Given this list of marker genes Cma1, Mindy1, Camk2d, Eif3m, Agbl5, Zfp696, Gas2, Fas, Hyal1, Slc35b4 (solute carrier family 35, member B4), Polr1c (polymerase (RNA) I polypeptide C), Srebf1, Dnaja1, Slc25a20, Psmd5, Cbx4, Ufd1 (ubiquitin recognition factor in ER-associated degradation 1), Sec23ip, Gm11626, Aim2, Mob1a, Eif4a3, Atf2, Aaas, Atad2, Vps4b, Zfp750, Gm12671, Tspan11, B130034C11Rik, Rgs18, Huwe1, Zkscan2, Fbxw22, Lce3c, Dpf2, Shfl, Tomt, H2-K2, Rhbdf1, Tacc3, Sec16a, Nlrx1, Rps3a1, 1700016P03Rik, Ubr1, Thsd7b (thrombospondin, type I, domain containing 7B), Aspa, Mms22l, Slc22a12, 4930515G01Rik, Rrp1b, Cask, 4933439C10Rik, Gm8066, Cul9, Sardh, Tef, Dnajc9, Klk5, Spdl1, Zfp335os, Smc1b, 2810402E24Rik, Kcnj15, Slc39a9, Cdk12, Bend3, Sympk, 4833439L19Rik, Angel1, 6430590A07Rik, Fosl2, Mink1, Ssbp1, Ddx23, Gm11993, Sorbs2, Mrpl57, Zfpm1, Gm28047, Cntln, Fam234a, Thap2, Tas1r1, Usp50, Ints13, Uap1, Irx2, Cryba1, Gm47512, Phlda3, Cfap161, St6galnac6, Atpaf1, Cntnap2, Opcml, Gm11185, Rictor, Cyfip1 (NCBI Gene Id 29878), Ift57, Cyb5d1, Ssr4, Spata2, Hspa4, Fam120a, Or8b12, Plekha7, Irag1, Dglucy, Stk11ip (serine/threonine kinase 11 interacting protein), Mau2, AA543401, Gm7164, Gm53, Uba6, H2-M2 (NCBI Gene Id 14990), Ddhd2, Gm4994, Hccs, Eif1-ps3, Trim35, Rpl10a, Ss18l2 (SS18, nBAF chromatin remodeling complex subunit like 2), Cnppd1, Kin, Slc1a2, Dusp26, Cct5, Gm9531, Mir3092, Nipsnap3a, Wrap53, Grk4, Mroh4, Gpr119, Rfk, Vtn, 4930539J05Rik, Hsbp1, Dlec1, 4930589L23Rik, Mroh5, Kpna3, Ctxn1, Cit, Septin7, Hk1, Gm12295, Gm13261, Kmt5b, Zbtb40, Alcam, Calm3, Ino80e, Cdc45, Cct8, Pcsk2os2, Sap18 (Sin3-associated polypeptide 18), Prdx3, Mast4, Snhg6, Srpk2, Arf3, Meig1, Stxbp4, Atp5f1c, Sgcb, Stard3nl, Txndc12, Naa30, Supt5, Cd86, Dynll1, Ppfibp1, Lman2l, Vezt, Gm20186, Pdia5, Brd2, Cdc5l, Snf8, Sgk2, Tktl1, Asxl1, Slamf9, Fam228b, Ikzf5, Gpcpd1, 3110083C13Rik, Mapk8ip3, Cnot3, Cdk8, Copb2, Slc12a9, Urb2, Gm19057, Dars1, Akap11, Pign, Phlpp1, Noa1, Tspan2os, Gm15576, Tipin, Ifi30, Cenpt, Mtmr3, Ssmem1 (NCBI Gene Id 75647), Lsm3, Xpc, Cox11, Ccdc92, Cpeb3, Hspa1b, Dennd2c, Agtpbp1, Pfkfb2, Mir7014, Nr3c2, Nubp2, A630023P12Rik, Rpl27, Puf60, Mir5133, Kazald1, Mkx, Tada3, Zfp661, B630019A10Rik, Smtn, Anapc13, Naa38, Rasl10b, Arap1, Lamp1, Senp2, Sidt2, Glmn, Wif1, Atpsckmt, Rnf8, Phf12, Ei24, Nudt19, Rangap1, Kdm1a, Smg5, Polr2l, Frmd4a, Med22, Phf19, Snord87, Tardbp, Dusp2, AY702102, Apoc2, Gm7933, M1ap, L1td1, Nuf2, Wdr11, Hc, Mcph1 (NCBI Gene Id 71346), Gm12503, Plcb1, Mgam, Acox1, Pum3, 4930401O10Rik, Agl, Trp53i13, Trim28, Tmem169, Fnip2, Thap12, Cetn3, Rfx7, Corin, Ldlrad2, 4930425O10Rik, Foxa2, Sned1, Cspp1, Mrpl40, Micos10, Exo5, Yipf3, Adipoq, 1700025G04Rik, Mapk14, Mpc2, Focad, AW551984, Ppp4r3b, Gm18382, A630023A22Rik, Pls1, Katnal1, Gm29398, Clk1, Gm32200, 1700112K13Rik, Adnp, Fgfr1, Cpne2, Vps13d, Qrich1, Irx5, Snx1, Bap1, Pms2, Rfx1 (regulatory factor X, 1 (influences HLA class II expression)), Rbm15, Ppp1cc, Bbc3, Fkbp5, Gm10638, Slc4a2, Csnk1g3, Zfp414, Nmrk1, Nsun3, Atf7, Dhx29, Ciapin1, Rpe (ribulose-5-phosphate-3-epimerase), Naa35, Rbm39, Ankfy1, Oxct1as, Mir3107 (NCBI Gene Id 100526510), Styxl1, Uqcc6, Dock3 (NCBI Gene Id 638531), Rab3b, Thap7, Fam110b, Depdc1a (DEP domain containing 1a), Arhgef40, Smarcc1, Nxpe4, Ano6, Gm26560, 9030622O22Rik (NCBI Gene Id 71570), Rpl26, Smg9, A530072M11Rik, Myo7a, 1110002J07Rik, Inpp4a, Ap1b1, Iqca1, Ribc2, Lrp5, Kdelr3, Polr2b, Gm8801, Nudt1, Gstt1, Trpv3, Rpl7a (NCBI Gene Id 30787), Dram1, Ccl17, Rps28, Brd4, Abcg2, Gpatch3, Or6d12, Mycbp2, Kif15, Rps19, Rtkn, Mrpl38, Acly, Atxn2, Xntrpc, Map2k5, 5530401A14Rik, Rps7, Gm23969, Rnpc3, Tshz3, C130013H08Rik, I830077J02Rik, Shmt1, Ecm1, Map4k4, Armc6, Slc66a1 (NCBI Gene Id 212555), Arl15, Rnf4, Rpl23a-ps13, Myo1b, 2310001K24Rik, Gm11515, Atp6v1f, Xndc1, Smdt1, Spag16, Ino80, Ppp5c, Vstm4 (NCBI Gene Id 320736), Bpifb6, Mtrex, Mir3071, Gm15246, Fam76a, Csnk1a1, Iqce, Dlgap2, Slc25a18, Tmem129, Egfl7, Pfn4, Gm15927, Mtf2, Pgpep1l, Mdga1, Gm26064, Wdr6, Btbd10, Lrsam1, Btf3l4, Sema3f, Nup214, Nfatc2, Usp48, Plcd3, Gstm1, Ecd, Apex2, Psd3, Glra3, Rtraf, Hnrnpk, Cnih4, Hmgcr, Styk1, AW112010, Crebzf, Fcnaos, Psmb2, Cntnap3, Diaph2, mt-Tp, Zfp286, Gtf2b, Map3k7, Tns3, Atp5pb, BB014433, Nlrp3, Cip2a, Asb15, Mir3077, Gm15165, Kmt2d, Gm12089, Mapk6, Cda, Tmem25, Eri3, Gm5702, Matr3, Lrrc3, Setx, Kmt2b, Cep63, Ermap, Ube2f, Dzip3, B4galnt2, Uhrf2 (NCBI Gene Id 76468), Rpl12, Relch, Btbd2, Mcrip1, Slc1a7, Ttn, Obox4-ps29, Atp1b1, Mir6919, Gm20770, Atp6v0a1, Slc15a4, Mdh2, Gm7369, Acaca, Ccdc71, Sugp1, Zfp185, Ano1, Flicr, Ireb2, Nup54, Or10al3, Zfp422 (NCBI Gene Id 67255), Rplp1, Denr, Serpinc1, Dis3, Dnajc27, Gm8802, Zfp664, Gm29328, Gm17484, Ralgds, Cltc (clathrin heavy chain), Sirt6 (NCBI Gene Id 72769), Fadd, Gpr165, Mief1, AI854703, Exosc10, Acadsb, Tasor2, Dbr1, Smim22, Ptpn4, Rps14, Mir674, Cnksr3, Fgfr1op2, Gm13983, Prkcsh, Klhdc8b, Srcap, Ctdsp1, Odf2, Creld2, Zkscan17, Ppp1r3f, Kif24, Tmco1, Zcwpw2, Zmynd8, Nenf, Mir34a, Rps15a, Megf6, Gm15374, Gm10463, Ube2d3, Dleu2, Cnot8 (CCR4-NOT transcription complex, subunit 8), Coq9, Luc7l2, Zfp217, Sugp2, Mbtd1, Dcaf6, Rmi1, Idh3g, Prdx1, Fancf, Azi2, Gm13042, Camsap1, Abca4, Pld3, Acot8, Dhcr7 (7-dehydrocholesterol reductase), Polr2e, Gm23527, Depdc5, Lsm14a, B230354K17Rik, Prkab2, Mpp3, Spsb3, Rfesd, Rap2a, Nr6a1, Pradc1, Cdhr2, Hnrnph3, Zzz3, Coro1c, Fabp7, Haspin, Ptprk, Ints14, Gm16124, Cad, H4c6, Stard9, Akt2, Gm12696, Krtap3-3, Vmn1r-ps28, Erh, Jade1, Lrrc27, Suv39h1, 4930579K19Rik, Cct7, Nop14, Wdr77, Kntc1, Tpm2, Xpot, 1700003F12Rik, Gm9946, Edrf1, Abi1, Gm10687, Ppid, Prpf39, Lamtor3, Cpsf1, Nvl, Fubp1, H2bc12, Gm12502, Rraga, Or5ac16, Syt12, Hira, Il5, Cdc25a, Gm23010, Kansl1, Colq, Crnde, Cars1, Gm12072, Nr5a1, Gm10631, Mre11a, Nudt2, Mir673, Sh3bgrl2, 4933433G15Rik, Lhfpl6, Dnajb7, Thrap3, Mdga2, Caprin1, Rc3h2, Trappc2, Etv4, Tspan4, Fgf2, Hand1, Parp4, Ahdc1, Kif2b, Tsc22d4, Or1n1b (olfactory receptor family 1 subfamily N member 1B), Gpr4, Micu2, Pde4a, L3mbtl1, Alg9, Zfp24, Ctnnb1, Mcts2, Ofd1, Gdi2, Pbld2, Tcf3, Foxa3, Trbv1, Bod1l, Bend4, Ap2a1, Ctnna1 (catenin alpha 1), Slc2a3, Mybbp1a, Git2, Ccdc62, Cul5, Emid1, Ska3, Trav7-6, Tyw5, Afap1l2, Tmem200b, Gtf2h4, mt-Tt, Arpp19, Ndufa7, Ercc6l2, Bcas1, Emc6, Igfn1, Spaca7b, Hirip3, Chrna9, Cln6, Ripk2, Scamp5, Gm13830, Cxcl17, Klhdc2, Tmem209, Zdhhc24, Zfp566, Madd, Arf1, Tmcc2, 4933409G03Rik, Eif5, Repin1, Ramac (RNA guanine-7 methyltransferase activating subunit), Sertad2, Abhd18, Golm2, Zfand4, Hoxb3, Ncoa4, Tln1, Zfc3h1, Myef2, Fbxl2, Lpin2, Gm12990, 1600012H06Rik, Tasor, Lsm8, Dnajb4 (DnaJ heat shock protein family (Hsp40) member B4), Tmem74, Prdm4, Gm22353, Cntn2, Nol9, Rpl21-ps1, Alg12, Cdc25c, Tspyl1, Ppp1r16a, 2510009E07Rik, Eif3h, Trpm8, Slc25a4, Gas2l1, Ttf2, Mycn, Rassf8, Arhgef1, Mmd, Paqr6, Psg25, Ppip5k1, Glce, Rbm26, Ddx20, Gm15889, Ddx60, Mad1l1, A430018G15Rik, Ttc14, Ptprd, Ppp1r16b, Ubr3, Stau2, here is a description of the gene set: species: Mus musculus Mouse Gene Set: PRDM9_TARGET_GENES from publication Yevshin I, Sharipov R, Kolmykov S, Kondrakhin Y, Kolpakov F (PMID 30445619) Genes containing one or more binding sites for (Prdm9) in their promoter regions (TSS -1000,+100 bp) as identified by GTRD version 20.06 ChIP-seq harmonization.